The following is a description of a gene set: Genes down-regulated in intestinal crypt cells upon deletion of CTNNB1. The Wnt signaling pathway is deregulated in over 90% of human colorectal cancers. beta-Catenin, the central signal transducer of the Wnt pathway, can directly modulate gene expression by interacting with transcription factors of the TCF/LEF family. In the present study we investigate the role of Wnt signaling in the homeostasis of intestinal epithelium by using tissue-specific, inducible beta-catenin gene ablation in adult mice. Block of Wnt/beta-catenin signaling resulted in rapid loss of transient-amplifying cells and crypt structures. Importantly, intestinal stem cells were induced to terminally differentiate upon deletion of beta-catenin, resulting in a complete block of intestinal homeostasis and fatal loss of intestinal function. Transcriptional profiling of mutant crypt mRNA isolated by laser capture microdissection confirmed those observations and allowed us to identify genes potentially responsible for the functional preservation of intestinal stem cells. Our data demonstrate an essential requirement of Wnt/beta-catenin signaling for the maintenance of the intestinal epithelium in the adult organism. This challenges attempts to target aberrant Wnt signaling as a new therapeutic strategy to treat colorectal cancer. Human Gene Set: FEVR_CTNNB1_TARGETS_DN from publication Fevr T, Robine S, Louvard D, Huelsken J (PMID 17785439) studied in species Homo sapiens, and this is the list of marker genes: P2RY6, PPP2CA, C5orf24, SNX5, CCT3, POLA1, DCK, NUTF2, ARF6, PCNA, MTBP, HADH, HNRNPAB, NUF2, DNAAF2, GNAI3, CYP3A5, SMYD4, HAT1, WEE1, KIF5B, AAGAB, AQP4, PRELP, RAD21, MEIS2, ELP1, INVS, EEF1D, TCF12, DLD, EIF5, PPP1CB, NAA15, RAD51AP1 (RAD51 associated protein 1), BRCA2, NOLC1, PCLAF, TRMT6, MRPL1, BCL7C, CES1, RWDD3, MACROH2A1, TRAIP, NDUFAF1 (NADH:ubiquinone oxidoreductase complex assembly factor 1), AHCYL1, GSTM1, PRIM1, SRSF3 (NCBI Gene Id 6428), CLDN2, EIF4A1, LIPT2, MCM4, POLD2, TMPO, LPP, SDC4, DCTD, LUC7L, FBXO5, YWHAZ, UTP3, SLBP, PRDX4, CPT1A, RIDA, NCAPD2, DHX15, FOXM1, TMEFF1, NRM, COQ8A, MAGT1, HMGN2, CREB1, MSI2, TUBE1, ADD3, H2BC18, TRIP13 (thyroid hormone receptor interactor 13), ANAPC5, UBE2E3, PMS1, IMPA2, ETAA1, ADSL, SNRPB2 (NCBI Gene Id 6629), CCP110, CDC25C, SLC37A2, ZGRF1, GMPS (guanine monophosphate synthase), CTC1, ZNF148, CASP8AP2 (caspase 8 associated protein 2), MATN2, CAPRIN1, SQOR, WDR12, HMGN1, CMSS1, H2AC7, CYP2C18, MELK, PABPC1, CENPW, CENPH, SRRM1, CDC7, MSH3, FRAS1, EIF2S3, AQP1, HMGA2, SLC4A7, TAF9, CDK1, RBBP4, CRP, FZD1, PAICS, PPAT, TFAM, PRPF4, DRG1, SLC25A5, TFB2M, SLC19A1, CYBRD1, GTPBP4, RFC4, TOP2A, LRAT, HSF1, TPMT (NCBI Gene Id 7172), CCNB2, EZH2, SARNP, CBLL1, PPARG, CIP2A, PWP2, BCAS2, FBL, KIF20A, DIS3, SOX4, VBP1, NEUROG3 (NCBI Gene Id 50674), PSMA1, INCENP, LIMD1, RPS24, KNTC1, ERH, CDC6, EIF3L, CA2, SGPP1, PECR, GLRX3, SMC6, SHMT1, RB1CC1, ZNF277, MTRR (NCBI Gene Id 4552), HPF1, PNN, CHEK1, POLD1, GTPBP10, SCARB1, SPATA24, CCT2, MTHFD1, RGCC, CENPO, PDS5B, XRN2, ZFHX3, SYT11, TUBA4A, IDE, FAM136A, CENPL, CHAF1B, RPS6KA6, MCM3, APEX1, RTL10, RRM1, SMYD2, EED, EIF3E, EXO1, TUBB, POLE2, ICE1, RPGR, CDKN3, PPP2R5E, PAPSS2, CENPP, KIF23, CKAP2, CENPE, CCT5, DNMT1, FGF1, CBFB, SFRP5, CARNMT1, ESRRG, LBR, NFIX, KCNQ1, ABHD17B, CNN3, AXIN2, RRS1, G2E3, BCOR, NUP155, BUB1, BLTP2, ASCL2, HAUS6, SYCP3, FAM169BP, ZNF548, MKI67, CTCF, SLC13A1, MCM6 (NCBI Gene Id 4175), SCLT1, STMN1, PTEN, HNRNPR, SP1 (NCBI Gene Id 6667), HELLS, PQBP1, RGS12, HIKESHI, TCP1, ACP2, EHF, ADRA2A, PRMT1, GCFC2, NINL, FEN1, CNNM3, ASF1B, SH3BGRL, CAPRIN2, LARP4, KCNN4, SFPQ, DCAF17, DMD, HBA2, DEK, MSH2, PRPS2, SRSF6, CNOT7, CBX1, REG4, DHFR, LRIG1, AFP, CUBN, SLC40A1, ROR2, BIRC5, ENPP3, MCM5, SECTM1, TMPRSS15, NOTCH1, RPL32, PITRM1, IFT70A, GINS1, HMGB2, FKBP3, ZNF593, KNSTRN, GFER, RASA3, SLC12A2, MTF2, KDM1B, CMTR2 (NCBI Gene Id 55783), VRK2, SCOC, DDX1, RAD1, EIF2A, ZNHIT6, LARP7 (La ribonucleoprotein 7, transcriptional regulator), HDGF, VMA21, ZFP62, USP14, DDX5, CD2AP, MIS18BP1, ACP1, LYPLA1, SDC2, PRC1, MCM2, EIF3A, DIAPH3, UCHL3, CCT4, TIAM1, RPL12, METTL13, DHX36, FIGNL1, KIF22, TCF19, PLA2G4A, CTBP2, GNPNAT1, KPNA2, SKP2, PA2G4, C5orf34, TRNT1, KAT2A, CYP3A43, STRAP, KIF18A, TRIP6 (NCBI Gene Id 96624), SF3B1, HAUS8 (NCBI Gene Id 93323), LSM5, PSMC3IP, FBP1, RMDN3, ILF3, PKDCC, NSMCE4A, ERGIC1, PRIM2, ADA, PDX1, PIWIL2, RSRC2, SOS2, BRCA1, RRM2, SSRP1, CYP2C9, NUP62, GEMIN4, GART, ZDHHC2, AKR1B1, NOP58, RRP1B, CDCA4, POLB, RNF138, RPL3, H2AZ1, DTYMK, GCDH, EPHB2, BTF3, SNRPD1, MOGS, EVL, HMGN5, FASTKD2, TGFBR1, MRE11, SET, HMGB1, IVD, LIG1, HBB, UNG, BORA, TRIM27, POLR1F, PFKP, LSM2, CCNE2, USP1, REG1A, SOX9, SPAG5, PHGDH, MRPL3, CTPS1, NMRAL1, THOC1, TRIM37, E2F1, RRP15, PSMB7, CRIM1, MATR3, RBMXL1, KIFC1, TTK, AURKB, CCNA2, SRSF2, CCND2, HEMGN, U2SURP, SEMA5A, ARHGAP27 (NCBI Gene Id 374805), CLPX, NOTCH2, SFRP1, EIF3F, COA6, CRYM, TRIM28, SMYD5, HMGB3, NUP210, OTC, CDO1, EIF3M, CENPI, EPHB3, RUVBL1, CHEK2, UBQLN2 (ubiquilin 2), CDV3, TOX, PIK3R1, BUB1B, EPHB4, RAD51, ROCK1, SF3A3, SLC18A2, CENPK, TIMELESS, PPP2R3A, SRSF1, RFC3, EIF2S1, SMARCA5, IFITM2, SPPL2A, RFC1, RAB1A, SMOC2, NCL, HASPIN, ANKRD10, NACA, IMPDH2, FGD1, CETN3, ZNF24, CHTF18, NAP1L1, CDC20, CBX5, PPID, GJB3, SSB, UCHL5, CDT1, NASP (NCBI Gene Id 96573), ZNF207, ORC6, MRPS22, GRSF1, PSMA6, TYMS, NRIP1, MSH6, POLE, FGFBP1, CFAP20, RFC2, RACGAP1, CFAP144P1, SMC1A, ECT2, HDAC2, MCM7, WTAP, DSCC1, CFI, GRWD1, AP3B1, TMA16, NCOA4, IFT70B, PCDH8, EEFSEC, MRPL13, IFFO2, ARHGAP5, ACAT2, RHOBTB3, CARD11, CD44, TM9SF2, MYB, DERPC, EIF2S2, HGH1, HSPA8, STYX, E2F5, MBNL3, ARGLU1, CTNNB1, DDX21, POLR1B, ALG6, TRMT11, ATP5PF, SMC3, SERPINE2, NXT1, SMPD4, XPO1, NNT, LIPG, TUBGCP2, CSRP2, CCND1 (NCBI Gene Id 893), TMEM107, NOP56, EGFR, PAPOLA (poly(A) polymerase alpha), RAD54L, KCNE3, TERF1, UBAP1, DDIAS, RSF1, SHCBP1, SP3, APPBP2, SRSF7 (NCBI Gene Id 87459), SKA1, ELF2, AASDHPPT, RPA1